Given this list of marker genes CYFIP2, PLAUR (NCBI Gene Id 5329), DDB2, COMT, CHAF1B, TRIM31, VCAM1, KIF14, SNCA (synuclein alpha), POM121, SLC2A5 (solute carrier family 2 member 5), TPM1, TCN2, VARS1, CSK, ISCU, SEPTIN4, DGKZ, PIM1, MDM2, GLT8D1, MLF2, SLC4A1, NPRL3, ATRX, RNPEP, F2R, CKAP2L, KRT8, GPM6B, REN, HBEGF, KIF21B, here is a description of the gene set: studied in species Homo sapiens Human Gene Set: CEBALLOS_TARGETS_OF_TP53_AND_MYC_DN We have previously demonstrated that c-Myc impairs p53-mediated apoptosis in K562 human leukemia cells, which lack ARF. To investigate the mechanisms by which c-Myc protects from p53-mediated apoptosis, we used K562 cells that conditionally express c-Myc and harbor a temperature-sensitive allele of p53. Gene expression profiles of cells expressing wild-type conformation p53 in the presence of either uninduced or induced c-Myc were analysed by cDNA microarrays. The results show that multiple p53 target genes are downregulated when c-Myc is present, including p21WAF1, MDM2, PERP, NOXA, GADD45, DDB2, PIR121 and p53R2. Also, a number of genes that are upregulated by c-Myc in cells expressing wild-type conformation p53 encode chaperones related to cell death protection as HSP105, HSP90 and HSP27. Both downregulation of p53 target genes and upregulation of chaperones could explain the inhibition of apoptosis observed in K562 cells with ectopic c-Myc. Myc-mediated impairment of p53 transactivation was not restricted to K562 cells, but it was reproduced in a panel of human cancer cell lines derived from different tissues. Our data suggest that elevated levels of Myc counteract p53 activity in human tumor cells that lack ARF. This mechanism could contribute to explain the c-Myc deregulation frequently found in cancer. from publication Ceballos E, Muñoz-Alonso MJ, Berwanger B, Acosta JC, Hernández R, Krause M, Hartmann O, Eilers M, León J (PMID 15856024) Genes down-regulated in K562 cells (chronic myelogenous leukemia, CML) expressing TP53 and MYC.